The following is a description of a gene set: Any process that stops, prevents or reduces the duration or quality of sleep, a readily reversible state of reduced awareness and metabolic activity that occurs periodically in many animals. studied in species Mus musculus Mouse Gene Set: GOBP_NEGATIVE_REGULATION_OF_CIRCADIAN_SLEEP_WAKE_CYCLE_SLEEP, and this is the list of marker genes: Adora1, Drd1, Drd2, Ghrl, Ada